Given this list of marker genes Wdr83, Mir7071, Mylk3, Itfg1, Wdr83os, Gcdh, 4933402J07Rik, Gm42031, Gm6625, Lonp2, Orc6, Heatr3, Gm18602 (NCBI Gene Id 100417420), Prdx2, Gm10637, 4921524J17Rik, Nkd1, Get3, Gm24490, Gm39214, Man2b1, Gm16167, Sall1, N4bp1, 4930535O05Rik, Gm17910, Dnaja2, Cyld, Klf1, Tnpo2, Cks1brt, A230103J11Rik (NCBI Gene Id 320466), Phkb, Junb, Mir7069, Syce2, Gm27246, Dnase2a, Rnaseh2a, Cbln1, Vps35, Siah1a, Mir8109, 9430002A10Rik, Gng14, Hm629797, Gm27167, Gm22305, Zfp423, Or7c19, Gm22336 (predicted gene, 22336), Gm23904, Gpt2, Brd7, 1700120C18Rik, Fth-ps3, Dhps (deoxyhypusine synthase), Gm24781, Gm16177, Rtbdn, AA672651, Fbxw9, Gm5356, Snx20, Cnep1r1, Gm24212, Tent4b, Trir, Rps13-ps1, Gm10638, Gm25506, Mir8110, Mir7070, Neto2, Gm17995, Nod2, Best2, Gm2716, Zfp791, Gm19872, 2010110E17Rik, Rps6-ps2, Adcy7, Mast1, Hook2, Abcc12, here is a description of the gene set: species: Mus musculus Mouse Gene Set: chr8C3